The following is a description of a gene set: Human Gene Set: MORF_RAGE Neighborhood of RAGE species: Homo sapiens Neighborhood of RAGE renal tumor antigen in the MORF expression compendium, and this is the list of marker genes: RPS6KB2, ADAMTSL2, DGCR11, PVT1, CD8B, PRPH, TNP1, GGT5, ZNF500, CNTN1, LTK, BAHD1, SH2B1, CASP2, DAPK2, MYO9B, BCL2, USP19, AMFR, TNFRSF25, UGT2B15, SPTB, EFNA2, TMEM94, SLC12A4, GRK4, SLC13A2, ENTREP3, MT4, IMPA1, FANCG, TLN2, COLQ, AP2A2, CLOCK, TUBGCP4, ZKSCAN3, ENTREP1 (endosomal transmembrane epsin interactor 1), SDC3, CYP2C9, SLC6A7, SLC16A5, PAX8, IGSF9B, SSTR5, LINC00928, NTSR2, EML3, HAUS5, SLC30A1, HSPB2 (heat shock protein family B (small) member 2), EXTL3, TCF7, HTR7, ITIH4 (inter-alpha-trypsin inhibitor heavy chain 4), IFT140, MC2R, NEURL1, SLC6A9, KANK2, PCGF1 (polycomb group ring finger 1), PITPNM1, TBX5, PML, ADAM15, HSF4 (heat shock transcription factor 4), WWOX, MUSK, DDX11, RBM8A, NCKIPSD, ARC, CRYAA, PIGB, ECE2, CNTN2, DOK1, PRELID3A, B4GALT3, MTX1, MMP25, IGHMBP2, LBP, SLC30A3, DPT, PCBP3, PAIP2B, MGAT1, GRIK5, HTR4, PRSS16, LSM1, PTPN9, KLHL18, SPEF1, PAX9, KHNYN, ITPR2, F7, CALCOCO1, AQP5, CRHR2, RBBP8, MPP2, SLC4A3, GRIP2, CBARP, CAMK2B, ARSL, LMO1, CRCP, ALDOC, BPHL, GHITM, MR1, WDR62, SLC24A1, CRYBA4, TCOF1, NUDT3, IRF2BP1, TSPO2, CDK5R1, TM4SF5, ZNF592, SLC5A2, NFRKB, PIGR, LSM12, HOXD4 (NCBI Gene Id 50714), SIK3, ACKR2, MOK, FDXR (NCBI Gene Id 2232), SLC2A1, SIX3, TUB, ADD2, MSX1, ANKRD12, CARD10, JAK3 (NCBI Gene Id 3718), SLC22A24, KIFC3, GPR35, IKBKG, MYL2, CYP11A1